Given this list of marker genes XCL1, CXCL14, CCL3, C5, FPR1, FPR3, PLAUR, HRAS, CXCL10, CCL21, CCL15, PLD1, CCL20, PLAU, CXCL9, CCR5, SERPIND1, FOSL1, PPBP (NCBI Gene Id 90374), CXCL2, DEFB4A, RALA, CX3CL1, DEFB1, CXCL13, C5AR1, CXCL11, CCL11, CCL17, CXCL6, CCL4, CXCR4, CXCL8, ANOS1, NOVA1, CCL19, CXCR2, CX3CR1, CCL8, CCL13, C3AR1, LECT2, CCL7, PF4, FPR2, CXCL5 (C-X-C motif chemokine ligand 5), CCL2, CCL23, CCL18, IL16, IL1A, CXCR3, CCR1 (C-C motif chemokine receptor 1), CCR2, CXCL12, CXCL1, here is a description of the gene set: studied in species Homo sapiens Human Gene Set: MODULE_108 Genes in the cancer module 108.